Given this list of marker genes Tram1, Ubl4a, Nomo1, Bag6, Rab5if, Wnk1, Sec61a1, Emc9, Get1 (NCBI Gene Id 93958), Ccdc47, Emc1, Sgta, Emc8, Ncln, Tram1l1, Emc6, Get4, Emc2, Tmem147, Emc7, Emc3, Emc4, Wdr83os, Get3, Tmco1, Emc10, Mmgt1, Caml, Tram2, here is a description of the gene set: Mouse Gene Set: GOBP_PROTEIN_INSERTION_INTO_ER_MEMBRANE The process that results in incorporation of a protein into an endoplasmic reticulum (ER) membrane. It depends on specific topogenic sequences of amino acids that ensure that a protein acquires the proper orientation during its insertion into the ER membrane. species: Mus musculus